Given this list of marker genes TRIM6, CSDC2, BNC1, ADIRF, NAT8L, RBFOX1, CEMP1, CPA4, AGAP11, LRRN4, PDE7B-AS1, KLF2-DT, TNS2-AS1, TMEM191A, TMEM151A, C3, PTGIS, AOX1, MTUS1-DT, PCOLCE2, SMTNL2, CRB2, CARNS1, CERS3-AS1, SEMA3D, LRP2, CNTN6, PTPRD, TNFRSF8, EPS8L1 (EPS8 signaling adaptor L1), FAM110C, CAVIN2-AS1, HAS1, EGOT, TNNT1, SFTPD, RPL34P18, SULT1D1P, MUC16, ADAMTS20, FGF11, MSLN, WT1, WNT7B, TMEM255A, CFH, FGF18, QRFPR, WT1-AS, NEK5, AOX3P, SCNN1A, TM4SF1-AS1, PTGDS, KLK11, LINC03017, WNT2B, RSPO1, LINC02643, COL8A2, ARL4D, ITGA3, MYRF, NECAB1, SLPI, NPHS1, ACTRT3, WNT10A, SPHKAP, SNRPA1-DT, RAET1E (NCBI Gene Id 135250), COL11A1, DSC3, ALDH1A2, SILC1, EPCIP, KLK10, KCTD8, KLHL26, PTPRQ, TGM1, SCEL, GFPT2, PHYHIP (NCBI Gene Id 9796), MTND6P21, ICA1-AS1 (NCBI Gene Id 100509886), GRIN2A, ANAPC2, ENSG00000266397, here is a description of the gene set: The gene expression program underlying the specification of human cell types is of fundamental interest. The study authors generated human cell atlases of gene expression and chromatin accessibility in fetal tissues. For gene expression, the study authors applied three-level combinatorial indexing to >110 samples representing 15 organs, ultimately profiling ~4 million single cells. The study authors leveraged the literature and other atlases to identify and annotate hundreds of cell types and subtypes, both within and across tissues. Our analyses focused on organ-specific specializations of broadly distributed cell types (such as blood, endothelial, and epithelial), sites of fetal erythropoiesis (which notably included the adrenal gland), and integration with mouse developmental atlases (such as conserved specification of blood cells). These data represent a rich resource for the exploration of in vivo human gene expression in diverse tissues and cell types. Marker genes curated from the annotated cluster as represented in the Descartes Human Gene Expression During Development database. studied in species Homo sapiens from publication Cao J, O'Day DR, Pliner HA, Kingsley PD, Deng M, Daza RM, Zager MA, Aldinger KA, Blecher-Gonen R, Zhang F, Spielmann M, Palis J, Doherty D, Steemers FJ, Glass IA, Trapnell C, Shendure J (PMID 33184181) Human Gene Set: DESCARTES_FETAL_INTESTINE_MESOTHELIAL_CELLS